The following is a description of a gene set: studied in species Mus musculus Mouse Gene Set: GOBP_CHOLESTEROL_CATABOLIC_PROCESS The chemical reactions and pathways resulting in the breakdown of cholesterol, cholest-5-en-3 beta-ol, the principal sterol of vertebrates and the precursor of many steroids, including bile acids and steroid hormones., and this is the list of marker genes: Hsd3b7, Scarb1, Apoe, Cyp7a1, Cyp27a1, Cyp39a1, Cyp46a1, Akr1d1